The following is a description of a gene set: Genes predicted to be targets of miRBase v22 microRNA mmu_miR_877_5p in miRDB v6.0 with MirTarget v4 prediction scores > 80 (high confidence targets). studied in species Mus musculus Mouse Gene Set: MIR_877_5P from publication Chen Y, Wang X (PMID 31504780), and this is the list of marker genes: Kcnb2, Elf1, Atic, Marchf1, Nsd2, Fsd1l, Col6a3, Dpy19l1, Sez6l, Tpm1, Rnf168, Msantd5f6, Kdm4b, Nhlrc1, Map3k9, Nfatc1, Cdkn1b (cyclin dependent kinase inhibitor 1B), Ric1, Pakap, B020004C17Rik (NCBI Gene Id 432860), Ugp2, Pcm1, Trpv5, Padi1, Fxr2, Cul3, Mrpl57, Mpdu1, Chrnb4, Cyp7b1 (NCBI Gene Id 99900), Csnk1g3 (casein kinase 1, gamma 3), Timd4, Chchd1, Fbxo32, Heg1, Vldlr, Ncam1, Lrba, Fgg, Noxo1, Cdo1, Or52n4, Caml, Dip2b, Grk2, Mylk4, Recql (NCBI Gene Id 19691), Zc3h6, Ubxn7, Dock9, Ylpm1